Given this list of marker genes DYM, ATP7A, FGF13, SCN1B, CSGALNACT1, HCN1, GPC6, GABRA1, GABRG2, SCN2A, PCDH19, EZH2, SCN1A (sodium voltage-gated channel alpha subunit 1), FBN2, PRRT2, GABRD, SCN9A, STX1B, COL9A3, ADGRV1, DPYSL5, here is a description of the gene set: species: Homo sapiens Limited knee extension Human Gene Set: HP_LIMITED_KNEE_EXTENSION Reduced ability to extend (straighten) the knee joint.